Given this list of marker genes SLCO2A1, CLCNKA, KCNJ1, CLCNKB, BSND, SLC12A1, here is a description of the gene set: Human Gene Set: HP_HYPERPROSTAGLANDINURIA species: Homo sapiens Hyperprostaglandinuria An increased concentration of prostaglandin in the urine.